Given this list of marker genes Enpp7, Dgat1, Apoa1 (apolipoprotein A-I), Apoa2, Acat2, Abcg5, Prap1, Apoa4, Cldn15, Cldn2, Cyp8b1, Lep, Abcg8, Lpcat3, here is a description of the gene set: species: Mus musculus Any process that modulates the frequency, rate or extent of intestinal lipid absorption. Mouse Gene Set: GOBP_REGULATION_OF_INTESTINAL_LIPID_ABSORPTION